Given this list of marker genes Itgb3 (NCBI Gene Id 268495), Selenop, Serping1, Gtpbp2, Trf, Wdr1, Tor4a, Sccpdh, Tgfb3, Nhlrc2, Aplp2, Fam3c, Sod1, Serpinf2, Ppbp, Cd109, Psap, Vcl, Tgfb2, Actn2, Fgb, Tuba4a, Scg3, Spp2, Itih4, Sytl4, Tmx3, A2m, Alb, Tagln2, F8, Pdgfb, Pcyox1l, Clu (clusterin), Aldoa, Manf, Ecm1, Pros1, Pf4 (NCBI Gene Id 56744), Lhfpl2, Fermt3, Igf2, Plek, Phactr2, Fga, Apoh, Rab27b, Pcdh7, Calm2, Selp, Prkcg (NCBI Gene Id 18752), Orm2, Mmrn1, Fgg, Orm3, Vegfa (vascular endothelial growth factor A), Actg1, Maged2, Stx4a, Vegfc, Vti1b, Calm3, Tln1, Lefty2, Gas6, Serpina1b, Anxa5, Brpf3, Sparc, Cyb5r1, Plg, Chid1, Cdc37l1, Actn1, Apoa1, Cfd, Ctsw, Cd36, Fn1, Egf, Islr, Cd9, Tgfb1, Igf1, Lamp2, App, Rarres2, Stxbp2, Hgf, Endod1 (endonuclease domain containing 1), Pecam1, Ola1, Tmsb4x, Qsox1, Hrg, Prkcb, Calm1, Serpina3f, Vegfb, Thbs1, F5, Actn4, Cyrib, Itga2b, Abcc4, Ly6g6f, Ahsg, Lgals3bp, Timp3, Stxbp3, Apool, Cd63, Timp1, Srgn, Habp4, Vegfd, Kng2, Pdgfa, Clec3b, Vwf (NCBI Gene Id 330420), Orm1, Lefty1, Tex264, Serpine1, Flna, Itih3, A1bg, F13a1, Serpina1c, here is a description of the gene set: studied in species Mus musculus Mouse Gene Set: REACTOME_RESPONSE_TO_ELEVATED_PLATELET_CYTOSOLIC_CA2 Response to elevated platelet cytosolic Ca2+